The following is a description of a gene set: Mouse Gene Set: GOMF_MISMATCHED_DNA_BINDING species: Mus musculus Binding to a double-stranded DNA region containing one or more mismatches., and this is the list of marker genes: Tdg, Aptx, Msh4, Msh5, Mlh1, Pcna, Mutyh, Msh2, Tdg-ps (NCBI Gene Id 545124), Msh6, Pms2, Msh3